The following is a description of a gene set: Mouse Gene Set: GOBP_GLUTAMINE_TRANSPORT The directed movement of glutamine, 2-amino-4-carbamoylbutanoic acid, into, out of or within a cell, or between cells, by means of some agent such as a transporter or pore. species: Mus musculus, and this is the list of marker genes: Lep, Slc38a9, Slc38a1, Slc38a3, Slc1a5, Slc38a5, Slc38a6, Slc38a7, Slc38a2